Given this list of marker genes KANSL1, SNX14, AGA, MAX, RAB33B, ORC1, DVL3, TNNT1, B3GALT6, RAD21, BRAF, PIGS, TBCD, PPIB (NCBI Gene Id 5479), FLNB, B4GALT7, NXN, RASA2 (NCBI Gene Id 5922), TGFB3, SLC12A2, TRIP11, PLOD2, ACTB, HBA2, SLC5A7, MBTPS1, MYH3, NRAS, PYCR1, SOX5, ARL3, MYF5, ZFX, PTF1A, SPRED2 (NCBI Gene Id 200734), TRAF7, FZD2, TGFBR1, SPTAN1, FBN1, GPC4, NALCN, SMS, GTPBP2 (NCBI Gene Id 54676), RRAS, MAN2B1, FGFR2, PIEZO2, TNFRSF11B, NKAP, WNT5A, SV2A, PPP1R21 (NCBI Gene Id 129285), TPM2, SYT2, B3GAT3, TGFBR2, UBTF, MYO9A, GALNS, FN1, MED25, ROR2, SOX9, MAN1B1, HDAC4, GNPTG, HYOU1, LZTR1, ASH1L, SNAP25, HNRNPH2, ACP5, ZDHHC9, TBX3, TRPV4, VPS37A, SLC2A10, RMRP, RAF1, BRD4, HBA1, TGFB2, OBSL1, RRAS2, RAP1B, TGDS, RNF135, MEGF8, EVC2, RNU4-2, COG4, NEK1, GZF1, ZEB2, PPP1CB, MME, EVC, SIL1, GPC3, ATP7A, CHRM3, XYLT2, TOE1, BMP2, GORAB, RIT1, UPF3B, NEU1, LGI3, TRPS1, CBL, CBS, SMAD2 (SMAD family member 2), ZNF668, AGRN, ERI1, PLAA, PCGF2, BMP4, CHST3, MARS2, RPS6KA3, DYM, KRT5, HSPG2, SP7, SMAD3, VPS33A (VPS33A core subunit of CORVET and HOPS complexes), IHH, MBTPS2, CHAT, COL13A1, NOTCH2, GLB1, BGN, COL11A2, MAP2K1 (NCBI Gene Id 5604), VAMP1, UCHL1, NF1, CSF1R, PLEKHM1, FKBP10, AP1G1, DVL1, SLC25A1, MRAS, PTPN11, BMP1, TBX6, ATAD3A, ATP2B1, ARSB, TNFRSF11A, FBN2, SKI, HNRNPH1 (heterogeneous nuclear ribonucleoprotein H1), G6PC3, XYLT1, WNT7A, IL6ST, RAB3GAP2, SOS1, KRAS, COL2A1, GNPTAB, SOS2, SLC18A3, FAM149B1, TELO2, NKX3-2, GUSB, PYCR2, IPO8, MFAP5, KIF7, DDR2, SLC37A4, HRAS, here is a description of the gene set: Pectus carinatum Human Gene Set: HP_PECTUS_CARINATUM A deformity of the chest caused by overgrowth of the ribs and characterized by protrusion of the sternum. studied in species Homo sapiens